Given this list of marker genes KPNA2, KDM6A, KDM4B, TET3, MED12L, BIRC5, CREBBP, YAP1, CNOT7, TUT7, H3C15, TPRX1, H2BC12, CPEB1, H2AB1, EIF4G1, H2BC15, H2AC18, PRM1, H3C1, TUBB4B, DUXA, KDM5B, PRM2, H4C1, DIS3L2, H2BC3, KDM4C, PAIP2, DPPA4, TUT4, KDM4E, PAIP1, PADI6 (NCBI Gene Id 391011), H2AC6, CNOT11, H2BC13, CNOT8, KDM6B, CNOT6L, ZFP36L2, POLR2D, H2BC12L, UNG, EIF4B, EIF4E, STPG4, CNOT9, DUX4, MED13, METTL23, KDM1B, H2BC1 (NCBI Gene Id 255626), BTG4, CNOT2, H2AC7 (H2A clustered histone 7), EIF4A1, PABPN1, H2BC11, CNOT4, PABPN1L, DPPA3, TNKS1BP1, ZP2, ZSCAN4, H2AJ, EP300 (NCBI Gene Id 2033), DUXB, ELOC, DPPA2, FGF8, DICER1, CNOT10, TEAD4, H2BC14, SRPK1, AICDA, EIF4A2, CNOT6, CNOT3 (CCR4-NOT transcription complex subunit 3), H2BC5 (H2B clustered histone 5), H2AX, CNOT1, H2BC21, NPM2, NOBOX, H2BC17, H2AC4, H2BC4, TET2, EIF4A3, H2AZ2, LEUTX, TPRX2, H2AC14, KDM5A, H2BC9, H1-8, RPS2, TP53, H3-3A, PABPC1, HIRA, H2AC20, UHRF1 (NCBI Gene Id 96185), AGO2, TPRXL, ELL2, H2BC26, here is a description of the gene set: Fertilization of the oocyte triggers the maternal-to-zygotic transition (MZT, reviewed in Vastenhous et al. 2019), a series of events that degrades maternal mRNAs, alters chromatin to allow widespread transcription, and initiates transcription of the new zygotic genome (zygotic genome activation, ZGA, embryonic genome activation, EGA, reviewed in Wu and Vastenhouw 2020).<br>Immediately after fertilization, the oocyte completes the final stage of the second meiotic division and the resulting zygote contains separate female and male pronuclei. Within the male pronucleus, protamines are replaced by histones provided by the oocyte. A specific set of maternal mRNAs is degraded by maternally provided factors in a process called M-decay and DNA methylation is lost in both the male pronucleus and the female pronucleus. In mouse zygotes, male DNA methylation is lost in an active process in which cytidine deamination by AICDA (AID) and excision repair initially remove 5-methylcytidine residues, then remaining 5-methylcytidine residues are oxidized by TET3 and removed by base excision repair so that male DNA methylation begins to decrease before fusion of the male and female pronuclei. Maternal DNA methylation is passively lost by dilution over subsequent cell generations, yielding a blastocyst that has low male and female DNA methylation. In human embryos, DNA demethylation in male and female genomes is much faster and is complete by the 2-cell stage, suggesting that maternal DNA demethylation may occur at least partly actively.<br>In mouse embryos, methylation at histone H3 lysine-4 (H3K4me3), a mark of active chromatin, changes from broad regions that span genes in the maternal genome to peaks at the 5' and 3' ends of genes. Acetylation of H3K27, another mark of active chromatin, increases and methylation of H3K27 and H3K9, repressive marks, becomes reduced. The result is a permissive state of chromatin that produces the first transcription of the zygotic genome and continues into the pluripotent cells of the blastocyst.<br>Activation of transcription of the zygotic genome, called zygotic genome activation (ZGA) or embryonic genome activation (EGA), occurs in two phases: an initial minor phase followed by a major phase. In mouse zygotes and possibly in human zygotes, the minor phase starts at the 1-cell stage. In mice, the major phase occurs at the 2-cell stage; in humans the major phase occurs at the 8-cell stage. Surprisingly, many transcripts in the early embryo originate from the LTRs of endogenous retroviruses. The LTRs later become silenced after implantation of the embryo.<br>Developmental pluripotency-associated protein 2 (DPPA2), DPPA4, and Double homeobox protein 4 (DUX4, homolog of mouse Dux) are all key transcription factors that participate in initiating the first, minor wave of ZGA. DPPA2 and DPPA4 activate DUX4 and other genes. DUX4 is actually a small array of identical retroposed genes that were produced by reverse transcription in the germline. DUX4 acting with other factors then activates developmental regulators such as ZSCAN4, the double homeobox genes DUXA, DUXB, LEUTX, and the histone demethylase KDM4E. Significantly, DUX4 binds and activates bidirectional transcription from the LTRs of HERVL endogenous retroviruses and Mammalian Apparent LTRs (MaLRs). Interestingly, human DUX4 and its homolog mouse Dux bind species-specific LTRs, indicating that DUX4 and Dux are coevolving with the endogenous retroviruses in their respective genomes. DUX4 also binds and activates bidirectional transcription of species-specific pericentromeric repeats, the human HSATII repeats.<br>Activation of the zygotic genome produces factors that further degrade maternal mRNAs in a process called Z-decay Reactome Pathway: Maternal to zygotic transition (MZT) species: Homo sapiens part of: Developmental Biology